Given this list of marker genes Stag2, Smc3 (NCBI Gene Id 13006), Sgo2a, Rad21, Smc1a, Ddx11, here is a description of the gene set: A cohesin complex that mediates sister chromatid cohesion during mitosis; has a subunit composition distinct from that of the meiotic cohesin complex. Mouse Gene Set: GOCC_MITOTIC_COHESIN_COMPLEX species: Mus musculus